The following is a description of a gene set: species: Homo sapiens Human Gene Set: GOBP_DTTP_METABOLIC_PROCESS The chemical reactions and pathways involving dTTP, deoxyribosylthymine triphosphate., and this is the list of marker genes: TBPL1, CMPK2, DTYMK, DCTPP1, TYMS